Given this list of marker genes Qprt, Nadsyn1, Haao, Afmid (arylformamidase), Kynu, Kmo, Ido2, Ido1, Nmnat2, here is a description of the gene set: species: Mus musculus The chemical reactions and pathways resulting in the formation of nicotinamide adenine dinucleotide (NAD+), beginning with the catabolism of L-tryptophan into the precursor quinolinate. NAD+ is a coenzyme that interconverts with its reduced form, NADH, in many redox and catabolic reactions. Mouse Gene Set: GOBP_DE_NOVO_NAD_BIOSYNTHETIC_PROCESS_FROM_L_TRYPTOPHAN